The following is a description of a gene set: Human Gene Set: GSE37301_PRO_BCELL_VS_GRANULOCYTE_MONOCYTE_PROGENITOR_UP from publication Ramirez K, Chandler KJ, Spaulding C, Zandi S, Sigvardsson M, Graves BJ, Kee BL (PMID 22608498) Expression profiling of Rag2-deficient Ets1++ and Rag2-deficient Ets1-- mature NK cells and WT bone marrow progenitors, WT T cells, and WT Pro B cells studied in species Homo sapiens Genes up-regulated in pro-B cells versus granulocyte-monocyte progenitors., and this is the list of marker genes: GP5, DNAJB1, AIP, NUAK2, ADPGK, GPR83, SORCS2, RHOB, ABCA3, TCP11L2, CNN3, GPR146, POR, DUSP5, CD247, IFITM3, PROS1, HEXIM1, NFYC, TSGA13, CPNE4, ACAP3, FLACC1, TXK, THRB, SGK1, EXT1, ATF4, STXBP2, TINF2, MIR376C, FLRT2, MIRLET7B, VKORC1, ITIH5, VAT1, HSPA1A, SCEL, NEDD4, SNX9, TEX13A, DUSP1, PLCL2, SLC25A33, DUSP10, FBXL22, OTUD1, DENND2C, RGS2, KLHDC1, CDH19, TEX2, CYBRD1, KDM7A, AMPD1, GNG3, CEP85, PHLDA1, SLC30A4, PPP1R15A, PRF1, KCNH2, BTD, PRKCH, CDHR3, CFHR1, TRAPPC2L, SIPA1L2, PSMF1, PGAM2, RTN4RL1, SNORD14E, JUN, NEDD4L, SELENON, FAH, FHIP1A, PCDHB9, PAK5, SLC26A9 (solute carrier family 26 member 9), CDKL5, HMGCS2, CASK, MECP2, FOS, DDR1, IFT172, HEXB, DAPK1 (NCBI Gene Id 1612), CPM, SIDT1, FTO, CRY2, SLC35D1, SYDE1, LAMC1, SETD6, MAPK11, ESR1, GSTO1, TGFB1I1, TMCO5A, SCD5, MC1R, TMEM120B, ID3, PAIP2, EHD2, CD9, GPR132, ASZ1, GADD45B, GIMAP5, IFT25, IRS2, COG6, BACH1, FAM114A1, TSC22D1, ZNF394, ADRB2 (adrenoceptor beta 2), MPP7, SALL2, CD68, NDUFS5, SAAL1, PDE2A, TANC1, PARD6G, ACVR1C, MXD1, FAM107A, GBP2, FOSB, ATP1B1, TRIB2, HSD11B1, PAK1, ARRB1, PRSS58, SERINC5, KDM8, RASGRP4, ZFP36, RAMP1, ITPKC